The following is a description of a gene set: Reactome Pathway: Interleukin-10 signaling part of: Signaling by Interleukins This event has been computationally inferred from an event that has been demonstrated in another species.<p>The inference is based on the homology mapping from PANTHER. Briefly, reactions for which all involved PhysicalEntities (in input, output and catalyst) have a mapped orthologue/paralogue (for complexes at least 75% of components must have a mapping) are inferred to the other species. studied in species Mus musculus electronically inferred by orthology from the curated human pathway, and this is the list of marker genes: Tyk2, Il10ra, Il10